The following is a description of a gene set: Human Gene Set: chr22q12 studied in species Homo sapiens, and this is the list of marker genes: BBLNP2, YES1P1, AP1B1P1, TBC1D10A, MIR3200, RFPL4AP6, MIR3199-2, MYO18B-AS1, RN7SL757P, RNU6-338P, SYN3-AS1, OSBP2, SFI1, SF3A1, NIPSNAP1, LINC01638, SLC35E4, LL22NC01-81G9.3, CHEK2, RPS15AP37 (NCBI Gene Id 100271651), ENSG00000225676, RN7SL633P, CSF2RBP1, SMTN, MTCO2P20, APOL6, RNU6-810P, CABP7-DT, BPIFC, SLC5A4-AS1, DRG1, MTCO1P20, GAS2L1, RBFOX2, ENSG00000224404, CSF2RB, HPS4, MIR7109, CRYBA4, NCF4, RNU6-331P, TXN2, ACO2P1, RPS15AP38 (NCBI Gene Id 100271655), MTMR3, ENSG00000304686, PATZ1, RFPL3, RNU6-1219P, LINC01521, RNF185, TFIP11, TOM1 (NCBI Gene Id 10043), CASTOR1, HORMAD2, IGLVIVOR22-2, RPL13AP26, TIMP3, ZMAT5, RFPL1S, DEPDC5, EIF4ENIF1, ISCA2P1, MRPS16P3, CACNG2, RPL36P17, EIF4HP2, TMPRSS6, LINC01643, PITPNB, SELENOM, IL2RB, LINC01399, RNA5SP497, SNORA50B, RNU6-564P, ENSG00000229770, HORMAD2-AS1, RNU6-1066P, HMGB1P10, ZNRF3-IT1, RPL15P22, TUG1, ETFRF1P1, APOL2 (NCBI Gene Id 23780), PIK3IP1, PRR14L, LIF-AS1, TCN2, CPMER, LINC02559, NF2, LIMK2, THOC5, RPS3AP51, RNU6-201P, SEC14L2, MYO18B, MPST, C1QTNF6, ASCC2 (activating signal cointegrator 1 complex subunit 2), RHBDD3, TPST2, C22orf42, RGL4P1, APOL4, RNU7-167P, CACNG2-DT, IGLCOR22-2, FOXRED2, LIF, RNF185-AS1, RN7SL305P, MORC2, NEFH, ENSG00000303430, CNN2P1, C22orf31, LINC02885, SEZ6L, PES1, MIR5739, SEC14L6, UQCR10, MTATP6P20, CCDC117, GRK3, MIR4764, DUSP18, LINC01640, PVALB, TTC28, RTCB, LARGE-IT1 (LARGE intronic transcript 1), RN7SKP169, MIR548J, MB, CPSF1P1, SDC4P, RPS17P16, INPP5J, APOL1, MTFP1, SNORD42, RPEP4 (NCBI Gene Id 100420665), SLC5A4, EIF3D, RNU6-28P (NCBI Gene Id 100873756), MYH9-DT, RNA5SP496, LARGE1-AS1, SNRPNP2, YWHAH (NCBI Gene Id 7533), CABP7, HMGXB4, SYN3, EWSR1, ENSG00000230736, PISD, HMOX1, RN7SL20P, RFPL3S, MIATNB, RNU6-1128P, MIR3928, SIRPAP1, HSCB, RPS26P59, RN7SL162P, RNF215, TFIP11-DT, SEC14L4, EMID1, YWHAH-AS1, CRYBB1, MYH9, SRRD, SEZ6L-AS1, MIR6818, LARGE-AS1, RPS3AP55, GRK3-AS1, LINC02558, ASPHD2, ZNRF3, TTC28-AS1, IGLCOR22-1, ZNRF3-AS1, RN7SKP214, MORC2-AS1, MIR3909, RNA5SP494, ENSG00000181123, RASD2, MTCYBP34, SLC39A1P1, NCF4-AS1, MIR6069, MIR3199-1, PLA2G3, MN1, OSM, MIAT, LARGE1, APOL3, SLC5A1, H2AZP6, APOL5, AP1B1P2, RPS18P14 (NCBI Gene Id 100128535), XBP1, RPL17P52, LIF-AS2, CCDC157, RFPL2, TST, IFT27, MIR6819, NDUFA9P1, LINC02554, RFPL1, TRMT112P8, AP1B1, KREMEN1, FBXO7, RNA5SP495, MTND1P10, ISX, GAL3ST1, KCTD17, SEC14L3, MTCO3P20, SNORD125, RASL10A, CIMIP4, PIK3IP1-DT, MCM5